Given this list of marker genes Gadd45b, Slamf7, Dlk1, Ccr7, Itgae, Pak1, Gzmc, Mecp2, Adgre5, Cxcr3, Socs2, Il10 (NCBI Gene Id 16153), Ccr2, Rgs2, Pdcd1lg2, Crem, Fos, Jun, Ddx5, Tnfrsf18, Gpr83, Izumo1r, Ccr5, here is a description of the gene set: Mouse Gene Set: ONO_FOXP3_TARGETS_UP from publication Ono M, Yaguchi H, Ohkura N, Kitabayashi I, Nagamura Y, Nomura T, Miyachi Y, Tsukada T, Sakaguchi S (PMID 17377532) Genes up-regulated in CD4+ T lymphocytes transduced with FOXP3. studied in species Mus musculus Naturally arising CD25+CD4+ regulatory T cells (T(R) cells) are engaged in the maintenance of immunological self-tolerance and immune homeostasis by suppressing aberrant or excessive immune responses, such as autoimmune disease and allergy. T(R) cells specifically express the transcription factor Foxp3, a key regulator of T(R)-cell development and function. Ectopic expression of Foxp3 in conventional T cells is indeed sufficient to confer suppressive activity, repress the production of cytokines such as interleukin-2 (IL-2) and interferon-gamma (IFN-gamma), and upregulate T(R)-cell-associated molecules such as CD25, cytotoxic T-lymphocyte-associated antigen-4, and glucocorticoid-induced TNF-receptor-family-related protein. However, the method by which Foxp3 controls these molecular events has yet to be explained. Here we show that the transcription factor AML1 (acute myeloid leukaemia 1)/Runx1 (Runt-related transcription factor 1), which is crucially required for normal haematopoiesis including thymic T-cell development, activates IL-2 and IFN-gamma gene expression in conventional CD4+ T cells through binding to their respective promoters. In natural T(R) cells, Foxp3 interacts physically with AML1. Several lines of evidence support a model in which the interaction suppresses IL-2 and IFN-gamma production, upregulates T(R)-cell-associated molecules, and exerts suppressive activity. This transcriptional control of T(R)-cell function by an interaction between Foxp3 and AML1 can be exploited to control physiological and pathological T-cell-mediated immune responses.